Given this list of marker genes SOS1, BTC (betacellulin), ERBB4, NRAS, HBEGF, PRKCE, ERBB3, PTPN12, EGFR, NRG1, NRG3, HRAS, NRG2, GRB2, ERBB2 (NCBI Gene Id 2064, erb-b2 receptor tyrosine kinase 2), KRAS, EREG, NRG4, PRKCA, PRKCD, SHC1, EGF, here is a description of the gene set: part of: Signaling by ERBB2 All ERBB2 heterodimers, ERBB2:EGFR, ERBB2:ERBB3 and ERBB2:ERBB4, are able to activate RAF/MAP kinase cascade by recruiting SHC1 to phosphorylated C-tail tyrosine residues in either EGFR (Y1148 and Y1173), ERBB2 (Y1196, Y1221, Y1222 and Y1248), ERBB3 (Y1328) or ERBB4 (Y1188 and Y1242 in JM-A CYT1 isoform, Y1178 and Y1232 in JM-B CYT1 isoform, Y1172 and Y1226 in JM-A CYT2 isoform). SHC1 recruitment is followed by phosphorylation, and the phosphorylated SHC1 recruits GRB2:SOS1 complex, which leads to SOS1-mediated guanyl-nucleotide exchange on RAS and downstream activation of RAF and MAP kinases. Reactome Pathway: SHC1 events in ERBB2 signaling studied in species Homo sapiens